Given this list of marker genes Acacb, Kctd7, Fmr1, Grm2 (NCBI Gene Id 73983), Slc1a1, Slc7a11 (solute carrier family 7 (cationic amino acid transporter, y+ system), member 11), Gls, here is a description of the gene set: A homeostatic process involved in the maintenance of a steady state level of glutamate within a cell. Mouse Gene Set: GOBP_INTRACELLULAR_GLUTAMATE_HOMEOSTASIS species: Mus musculus